Given this list of marker genes Dmgdh, Sardh, Bhmt1b, Slc44a1, Chdh, Aldh7a1, Bhmt, here is a description of the gene set: Choline catabolism studied in species Mus musculus Mouse Gene Set: REACTOME_CHOLINE_CATABOLISM